The following is a description of a gene set: studied in species Mus musculus DNA double-strand breaks are generated by genotoxic agents and by cellular endonucleases as intermediates of several important physiological processes. The cellular response to genotoxic DNA breaks includes the activation of transcriptional programs known primarily to regulate cell-cycle checkpoints and cell survival. DNA double-strand breaks are generated in all developing lymphocytes during the assembly of antigen receptor genes, a process that is essential for normal lymphocyte development. Here we show that in murine lymphocytes these physiological DNA breaks activate a broad transcriptional program. This program transcends the canonical DNA double-strand break response and includes many genes that regulate diverse cellular processes important for lymphocyte development. Moreover, the expression of several of these genes is regulated similarly in response to genotoxic DNA damage. Thus, physiological DNA double-strand breaks provide cues that can regulate cell-type-specific processes not directly involved in maintaining the integrity of the genome, and genotoxic DNA breaks could disrupt normal cellular functions by corrupting these processes. Genes up-regulated in pre B lymphocyte after induction of physiological DNA double-strand breaks (DSB) by RAG2; the changes are independent of ATM signaling. Mouse Gene Set: BREDEMEYER_RAG_SIGNALING_NOT_VIA_ATM_UP from publication Bredemeyer AL, Helmink BA, Innes CL, Calderon B, McGinnis LM, Mahowald GK, Gapud EJ, Walker LM, Collins JB, Weaver BK, Mandik-Nayak L, Schreiber RD, Allen PM, May MJ, Paules RS, Bassing CH, Sleckman BP (PMID 18849970), and this is the list of marker genes: Iqcf1, Paip1, Pla2g4b (NCBI Gene Id 545452), Coq4, Pja1, Cep15, Isoc1, Smg1 (NCBI Gene Id 72492), Ccnd1, Gak, Hgsnat, Sned1, Kansl1l, Thoc1, Slc5a9, Maf, Notch2, Il12a, Timmdc1, Jade1, Bloc1s2 (biogenesis of lysosomal organelles complex-1, subunit 2), Sbspon, Xaf1, Ahcyl2, Pik3ap1, Cdhr2, Ctse, Maff, Cnrip1 (NCBI Gene Id 77064), Adat2, Pcdh11x, Prelid2, Gh (NCBI Gene Id 14599), Pi4kb, St6galnac2, Mpp7, Ky, Wasf2, Poglut1, Elovl6, Akr1c13, Sh3rf1, Acp3, Klhl14, Lsm12, Dock7, Crygn, Zfp14, Txndc15, Ccr5, Tmod4, Klhl7 (kelch-like 7), Cdc23, Ehd3 (EH-domain containing 3), Sgcb, Rab32, Edaradd, Slc20a1, Rnf157, Fam32a, Zc4h2, Shfl, Rcan1, Sec23ip, Cd244a